The following is a description of a gene set: A severe form of lactic acidemia. Human Gene Set: HP_SEVERE_LACTIC_ACIDOSIS species: Homo sapiens Severe lactic acidosis, and this is the list of marker genes: MT-TE, PDHA1, NDUFS4 (NADH:ubiquinone oxidoreductase subunit S4), COX16, SLC25A26, NDUFS2, RRM2B, SLC25A4, MT-TT, LRPPRC, BCS1L, TRMU (tRNA mitochondrial 2-thiouridylase), UQCC3, TSFM (NCBI Gene Id 10102)